Given this list of marker genes Cd47, Trem2, Sarm1, Plxnc1, C1ql1, Adgrb3, Vangl2, Kcnk13, Ngef, Cdk5, Epha4, Itgb1, here is a description of the gene set: Mouse Gene Set: GOBP_REGULATION_OF_SYNAPSE_PRUNING Any process that modulates the frequency, rate or extent of synapse pruning. studied in species Mus musculus